The following is a description of a gene set: studied in species Homo sapiens Human Gene Set: GOBP_POSITIVE_REGULATION_OF_CILIUM_MOVEMENT Any process that increases the rate, frequency, or extent of cilium movement, the directed, self-propelled movement of a cilium., and this is the list of marker genes: RNASE10, DEFB1, ADAM7, PRDM14, CFAP69, CCR6, TAC1, IRGC, TAC4, TTLL6, TACR2, TACR1, PGAM4, IQCF1, TACR3, TAC3